Given this list of marker genes GSK3A, PRKCB, FABP5, MIR103A1, PID1, MIR107, MIR143, INPP5K, ENPP1, SIRT6, IL1B, APPL2, LEP, CTNND1, TNF, RSC1A1, CERS1, PEA15, OSTN, SELENOS, STXBP3, GRB10, here is a description of the gene set: studied in species Homo sapiens Human Gene Set: GOBP_NEGATIVE_REGULATION_OF_D_GLUCOSE_TRANSMEMBRANE_TRANSPORT Any process that decreases the frequency, rate or extent of glucose transport across a membrane. Glucose transport is the directed movement of the hexose monosaccharide glucose into, out of or within a cell, or between cells, by means of some agent such as a transporter or pore.